Given this list of marker genes RBM8A, MAP3K7 (mitogen-activated protein kinase kinase kinase 7), FLNA, SALL4, TBX5, here is a description of the gene set: Aplasia/Hypoplasia involving the shoulder musculature Human Gene Set: HP_APLASIA_HYPOPLASIA_INVOLVING_THE_SHOULDER_MUSCULATURE Absence or underdevelopment of the muscles of the shoulder. studied in species Homo sapiens